Given this list of marker genes ABI1, ACTR2, WASF1, WASF2, WASF3, ACTB, CYTH4, ACTG1, CYTH3, NCKAP1, ACTR3, CYTH2, CYTH1 (cytohesin 1), ARPC5, ARPC3, ARF1, ARPC1A, ARPC4, BRK1, CYFIP1 (NCBI Gene Id 23191), ARPC1B, ARPC2, ARPC5L, ARF6, CYFIP2, here is a description of the gene set: Human Gene Set: KEGG_MEDICUS_REFERENCE_ARNO_ARF_ACTB_G_SIGNALING_PATHWAY ARNO-ARF-ACTB_G signaling pathway. Pathway ID: N01066. Pathway type: Reference. Pathway class: nt06135 Cytoskeletal regulation (viruses and bacteria). Pathway Definition from KEGG: ARNO -> ARF6 -> ARF1 -> (WASF+ABI1+HSPC300+CYFIP+NCKAP1) -> ARP2/3 -> (ACTB,ACTG1) species: Homo sapiens